Given this list of marker genes Sbspon, Adamts18, Adamts4, Adamtsl1, Adamtsl2, Adamts15 (NCBI Gene Id 235130), Spon1, Adamtsl5, Pofut2, Adamts13, Adamts1, Cfp, Adamtsl4, Thsd4, Sema5b, Thbs2, Adamts12, here is a description of the gene set: Reactome Pathway: O-glycosylation of TSR domain-containing proteins electronically inferred by orthology from the curated human pathway studied in species Mus musculus This event has been computationally inferred from an event that has been demonstrated in another species.<p>The inference is based on the homology mapping from PANTHER. Briefly, reactions for which all involved PhysicalEntities (in input, output and catalyst) have a mapped orthologue/paralogue (for complexes at least 75% of components must have a mapping) are inferred to the other species. part of: O-linked glycosylation